The following is a description of a gene set: Mouse Gene Set: GOBP_POSITIVE_REGULATION_OF_CELL_SUBSTRATE_ADHESION Any process that increases the frequency, rate or extent of cell-substrate adhesion. Cell-substrate adhesion is the attachment of a cell to the underlying substrate via adhesion molecules. studied in species Mus musculus, and this is the list of marker genes: Enpp2, Itga5, Ccl28, Myh9, Itga3 (integrin alpha 3), Gfus, Dbn1, Thbs1, Wnt4, Gsk3b, Cd3e, Fermt1, S100a10, Emp2, Ccl21d, P4hb, Ptpn11, Ccl21a, Plekha2 (NCBI Gene Id 97502), Cfl1 (NCBI Gene Id 12631), Crk, Ilk (integrin linked kinase), Col16a1 (NCBI Gene Id 72521), Trem1, Prkce, Tsc1, Arl2, Emilin1, Ccl21e, Smoc1, C1qbp, Prex1, Vit, Spp1, Ptprj, Spock2, Poldip2, Utrn, Cdh13, Cass4, Smoc2, Cripto, Hsd17b12, Crkl, Lims2, Myoc, Cib1, Smad3, Rac3, Kdr, Dnm2, Dicer1, Dock5, Abl1, Nedd9, Rsu1, Fut1, Npy, Ppm1f, Disc1, Agr2, Olfm4, Hrg, Fbln2, Apoa1, Alox15, Mdk, Fmn1, Calr, Arpc2, Rin2, Sdc4, Cd36, Vwc2, Ptn, Has2, Ccl21b, Triobp, Rell2, Abi3bp, Nid1, Pcsk5, Rreb1, Ccn1, Dab2, Myadm, Fermt2, Ccl25, Vegfa, Thy1, Npy2r, Rac1, Egflam, Efemp2, Tek, Npnt, Skap1, Dock1, Dag1, Prkcz (NCBI Gene Id 97193), Edil3, Col26a1, Plpp3, Ndnf, Egfl6, Unc13d, Cdc42, Tesk1, Stk4, Col8a1, Jup, Itgb3, Dmd (NCBI Gene Id 93863), Rras, Braf, Csf1, Map4k4, Vtn, Ccdc80, Ccl21f, Fn1, Itgb1, Dmp1, Itgb1bp1, Ptk2b, Rock1 (Rho-associated coiled-coil containing protein kinase 1), Lims1, Cspg5, Flna, Hacd1, Ninj1, Nrp1, Epb41l5, Sec1 (secretory blood group 1), L1cam, Cdk6, Jak2, Iqgap1, Itga6, Fbln1, Ecm2, Carmil1, Epha1, Foxf1, Pdgfb